The following is a description of a gene set: Human Gene Set: GOBP_CYCLIC_NUCLEOTIDE_CATABOLIC_PROCESS The chemical reactions and pathways resulting in the breakdown of a cyclic nucleotide, a nucleotide in which the phosphate group is in diester linkage to two positions on the sugar residue. studied in species Homo sapiens, and this is the list of marker genes: PDE4D, PDE4B, PDE9A, PDE8B, PDE8A, PDE2A, PDE7B, PDE7A, PDE10A, PDE4C, PDE1A, CNP, PDE4A, PDE5A